Given this list of marker genes TAF6, DTX4, ARHGAP22 (NCBI Gene Id 58504), ICAM3, SH3BGRL (NCBI Gene Id 96022), IQSEC2, USP12, OXSR1, ERCC1, KYAT1, AMHR2, WDFY3, LAGE3 (NCBI Gene Id 8270), SUMO2, PDIA4, TNFRSF9, RCBTB2, PRDX2, ATF5, RND3, RNASE2, MPP1, TMBIM6, BCAP31, PHF8, MUC6, CCR1, TACR1, SLC6A8, CACNA1H, LPL, MUC3A, RDH11, LY86, AOPEP, MDFIC, COIL, GGPS1, DMXL2, FKBP2, USP10, KLF10, ACP3, MGA, HSP90B1 (heat shock protein 90 beta family member 1), GUSB, MTCL2, ZC3H11A, ALDOC, KDM3A, RASA1, YTHDC1, CTDSPL, ADIPOR2 (adiponectin receptor 2), RPS6KA2 (ribosomal protein S6 kinase A2), SPINK4, EEF1B2, EIF3H, PGRMC2, EPB41L3, APOE, IFIT1 (NCBI Gene Id 8374), ZBTB1, URB2, ITGB5 (integrin subunit beta 5), STX5, NUMB, RPS5, CLN3, PPP1R12A, CTDSP2, FUBP1 (far upstream element binding protein 1), SLC7A7, STK10, PDE3B, TM9SF4, VAV1, LILRA2, HNMT, GSDME, NCL, MYL6B, CUL2, PRDX6, CETN2, CUL5, SELENOP, ZWINT, AIF1, MANF, IFI44, ARHGEF7, LY6G6D, ENC1, CD14, STT3A, GCLC, TSC22D3, KDELR2, MNDA, HDDC2, GSAP, AGA, SREBF2, MYD88, P4HA1, LDHA, DUSP14, TDRD3, FSHB, SDHB, STK38, GABARAP, METTL3, MTMR4, TIMP1, IFNA16, CDK3, PLIN2 (perilipin 2), USP15, DHRS3, SLC35A3, TSPYL2, SLC43A1, PLXND1, ARPC3, HSPA1A, ALDH5A1, PGM1, NREP, ITGAL, MRS2, FBL, ST3GAL6, CCL2, PTGER2, BTD, ALDH3A2 (NCBI Gene Id 224), RDX, EEF2, NASP, RPL6, ENO2, IDS, PIK3C3, LRRC8B, TSC22D1, CSF3R, RPS6, FCGR3A, AZIN1, TPP1, FAM153A, GLRX, CD55, TRAF3IP1, NSMAF, OGT, METAP1, MBD4, DNAJB1, PPM1H, IQGAP2, SLC11A1, CTBS (chitobiase), CCR5, RPL22 (ribosomal protein L22), STAB1, GPC4, ATF3, PHC2, BCKDHA, RNASE1, NAP1L1, ACP5, RPS6KA3, SELE, CD300A, CDK2AP2, DLEC1, TIAL1, GPNMB, ZC3HAV1, PPIF, GNRH2, SLC2A5, MSMO1, DDIT3, FYN, HERPUD1, GEM, USF2, RPL11, ACAT2, TRIM33, SOCS7, RPS6KA1, FRMD4B, CD9, SUPT4H1, here is a description of the gene set: Monocyte-derived dendritic cells (DC) and macrophages (MΦ) generated in vitro from the same individual blood donors were exposed to five different pathogens, and gene expression profiles were assessed by microarray analysis. Responses to Mycobacterium tuberculosis and to phylogenetically distinct protozoan (Leishmania major, L. donovani, Toxoplasma gondii) and helminth (Brugia malayi) parasites were examined, each of which produces chronic infections in humans yet vary considerably in the nature of the immune responses they trigger. Genes down-regulated in comparison of dendritic cells (DC) exposed to L. donovani versus macrophages exposed to L. donovani. studied in species Homo sapiens from publication Chaussabel D, Semnani RT, McDowell MA, Sacks D, Sher A, Nutman TB (PMID 12663451) Human Gene Set: GSE360_DC_VS_MAC_L_DONOVANI_DN